Given this list of marker genes Topbp1, Pip4k2b, Chm, Kat6a, Rad1 (NCBI Gene Id 19355), Ywhag, Rfc2, Ccng1, Cox7a2l, Map2k6, Chek1, Smyd2, Ercc2, Polr2k, Ssrp1, Pou4f2, Cox7a1, Taf4b, Top3a, Aurkb (aurora kinase B), Taf2 (TATA-box binding protein associated factor 2), Supt5, Tsc1, Tigar (NCBI Gene Id 97300), Cox6c, Prkaa2, Mnat1, Cnot7, Cox8c, Gtf2h4, Prelid3a, Ywhab, Ccnt1, Cdk5r1, Rfc5, Gpx2, Kat5, Csnk2a1, Pou4f1, Supt4a, Ttc5 (tetratricopeptide repeat domain 5), Cox7b, Rragd, Taf5, Rpa2, Rabggtb, Prdx2, Gtf2f1, Triap1, Prkab1, Taf13, Cox7c, Gtf2f2, Prkab2, Prmt5 (NCBI Gene Id 27374), Polr2d (polymerase (RNA) II (DNA directed) polypeptide D), Brip1, Gtf2h2, Prkag2, Plk3, Pcna, Polr2i, Sesn1, Eloa, Ccnt2, Gls2, Chd4, Nelfb, Taf15, Dna2, Cdkn1a, Nelfe, Pml, Cox5a, Steap3, Txn1, Npm1, Ndufa4 (NCBI Gene Id 17992), Mbd3, Stk11, Ppp2r1a, Polr2g, Rffl, Lamtor1, Pip4p1, Lamtor4, Brca1, Cox6a1, Akt3, Aurka, Trp53bp2, Csnk2b (NCBI Gene Id 13001), Cdc25c, Cox8a, Mtor, Rpa1, Rad9a, Nelfa, Cnot6l, Cox4i2, Tsc2, Cdk7, E2f7, Ubc, Rheb, Ing5, Ak6, Cdk12, Ywhaz, Tmem219, mt-Co3, Eloc, Cradd, Ehmt1, Ccne1, Jmy, mt-Co2, Chd3, Prelid1, Gadd45a, Gls, Brpf1, Taf1, Gpi1, Polr2c, Sfn, Rpa3, Polr2f, L3mbtl1, Kmt5a (lysine methyltransferase 5A), Ppp1r13b, Meaf6, Cnot3, Ubb, Cdk5, Rraga, Trp63, Rfc3, Lamtor3, Nelfcd, Taf12 (NCBI Gene Id 66464), Supt16, Usp7, Sesn2, Rad9b, Tbp, Taf6, Wrn, Akt2, Rbbp7, Ep300, Tnks1bp1, Nuak1, Cnot9, Ccnh, Pidd1, Daxx, Brd1, Ccna2, Cox5b, Gtf2h5, Rad17 (NCBI Gene Id 319242), Rabggta, Ywhaq, Igfbp3, Taf7, Gm10053 (predicted gene 10053), Trp53, Polr2h, Prdx5, Mdm4, Ccne2, Trp73, Cnot11 (CCR4-NOT transcription complex, subunit 11), Rptor, Cox6b1, Zfp385a, Bax, Csnk2a2, Brd7, Btg2, Gtf2h3, Hipk2, Casp2 (NCBI Gene Id 12366), Cdk13, Hus1, Ell, Ctdp1, Cdk2, Phf20, Dyrk2, Ddit4 (NCBI Gene Id 74747), Higd1c, Trp53rkb, Lamtor5, Ppp2cb, Hipk1, mt-Co1, Sgk1, Mdm2, Rhno1, Ywhah, Rictor, Prdx1, Hdac1, Ehmt2, Usp2, Taf9b, Cnot1, Rmi2, Noc2l, E2f8, Cenpj, Taf11, Sesn3, Bnip3l, Mapkap1, Mapkapk5, Cnot8, Bard1, Ccna1, Polr2a, Rnf34, Chek2 (checkpoint kinase 2), Cox7a2, Pdpk1 (NCBI Gene Id 18607), Ppp2r5c, Pin1, Cox6a2, Mta2 (metastasis-associated gene family, member 2), Txnrd1, Polr2l, Taf10, Cdk1, Cox4i1 (cytochrome c oxidase subunit 4I1), Tcea1, Mre11a, Zfp420, Plk2, Brpf3, Cnot6, Gtf2h1, Blm, Ppp2r1b, Banp, Rragc, Polr2e, Ercc3, Ccnb1, Mlst8, Lamtor2, Uba52rt, G6pdx, Cnot10, Rbbp8, Cnot4, Uba52, Ing2, Cycs, Rragb, Taf4, Cdkn1b, Taf3 (NCBI Gene Id 99383), Ywhae, Rps27a, Cdkn1c, Pip4k2a, Trp53inp1, Prkaa1, Prr5, Exo1, Pip4k2c, Cnot2, Gatad2b, Cdk9, Atm, Gatad2a (NCBI Gene Id 97459), Ccnk, Taf9, Prkag1, Tpx2, Rad50, Slc38a9, Atrip, Ppp1r13l, Ppp2ca, Elob, Mapk14, Akt1, Rbbp4, Mapk11, Polr2b, Cox6b2, Gsr, Nbn, Rfc4, Prkag3, Rmi1, here is a description of the gene set: Mouse Gene Set: REACTOME_TRANSCRIPTIONAL_REGULATION_BY_TP53 species: Mus musculus Transcriptional Regulation by TP53